The following is a description of a gene set: To better understand how innate immune responses to vaccination can lead to lasting protective immunity, we used a systems approach to define immune signatures in humans over 1 wk following MRKAd5/HIV vaccination that predicted subsequent HIV-specific T-cell responses. Within 24 h, striking increases in peripheral blood mononuclear cell gene expression associated with inflammation, IFN response, and myeloid cell trafficking occurred, and lymphocyte-specific transcripts decreased. These alterations were corroborated by marked serum inflammatory cytokine elevations and egress of circulating lymphocytes. Responses of vaccinees with preexisting adenovirus serotype 5 (Ad5) neutralizing antibodies were strongly attenuated, suggesting that enhanced HIV acquisition in Ad5-seropositive subgroups in the Step Study may relate to the lack of appropriate innate activation rather than to increased systemic immune activation. Importantly, patterns of chemoattractant cytokine responses at 24 h and alterations in 209 peripheral blood mononuclear cell transcripts at 72 h were predictive of subsequent induction and magnitude of HIV-specific CD8(+) T-cell responses. This systems approach provides a framework to compare innate responses induced by vectors, as shown here by contrasting the more rapid, robust response to MRKAd5/HIV with that to yellow fever vaccine. When applied iteratively, the findings may permit selection of HIV vaccine candidates eliciting innate immune response profiles more likely to drive HIV protective immunity. species: Homo sapiens Genes up-regulated in peripheral blood mononuclear cell Ad5 nAb titers >= 200Ad5 nAb titers <= 200 in adults (20-50) (Ad5 nAb titers > 200) after exposure to MRKAd5 HIV-1 gag/pol/nef, time point 1D. Comment: Impaired down-regulation. Genes with MRKAd5/HIV-induced expression responses significantly impacted by Ad5 nAbs (24hrs). Table includes specific cell types. Human Gene Set: ZAK_PBMC_MRKAD5_HIV_1_GAG_POL_NEF_AGE_20_50YO_AD5_NAB_TITERS_GTE_200_VS_LTE_200_1DY_UP from publication Zak DE, Andersen-Nissen E, Peterson ER, Sato A, Hamilton MK, Borgerding J, Krishnamurty AT, Chang JT, Adams DJ, Hensley TR, Salter AI, Morgan CA, Duerr AC, De Rosa SC, Aderem A, McElrath MJ (PMID 23151505), and this is the list of marker genes: MPRIP, NSA2 (NCBI Gene Id 10412), GPR174, TRGV3, C12orf57, PTGDR, TRAJ9, FCRL1, LDHB, TRAJ37, NT5E, SNORD4A, CSE1L, SESN3, TRBV19, PPIL3, PATJ, PRKACB, APBA2, DLEU1, SNORD8 (NCBI Gene Id 319103), TRAJ38, EIF3E, TRABD2A, NPAT, NAE1, THEMIS, RASGRP1, PSIP1, AK5, IP6K1, TRGJP1, STEAP4, SH2D1A, ZKSCAN8, KLRK1, G0S2, EIF3L, ITGB3BP, TRAV13-2, KLRD1, CD96, CAMK4, CD22, IPP, INPP4B, GTF2H3, CLEC2D, SCARNA5, TRAV20, RPL15, TRAV3, MGAT4A, ABCD2, GCC2, TRAV17, SESN1, ZNF506, FXR1, TRAJ41, TRAJ29, USP34, LRIF1, RORA, CYP27A1, TRAJ10 (NCBI Gene Id 28745), TRAJ48, CDCA7L, TRAJ5, TRAV8-2, ACADSB, HTATSF1, SKAP1, PAIP2B, RBL2, TRAJ40, NAP1L1, BMI1, ABLIM1, NAA16, SNORD5, TRAV41, SNORD4B, DENND4C, IGLV1-40, RPS13, TRAJ13, CRTAM, MAML2, TRAJ3, SLC4A7, KLRB1, KPNA4, KLRF1, NELL2 (neural EGFL like 2), DLGAP1-AS1 (DLGAP1 antisense RNA 1), LUC7L3, TRAV22, RCAN3, AHCTF1, BANK1, RNF125 (NCBI Gene Id 54941), H2AC8, ITGA6, DSC1, TTC3, MID2, ETS1, TLR10, PDE3B, TRAJ32 (NCBI Gene Id 28723), TRAJ36, TRAJ20, BCL2 (BCL2 apoptosis regulator), ZNF770, KLF12, N4BP2 (NEDD4 binding protein 2), NUCB2, TC2N, KLHDC2, TRAJ33, ERGIC2, SNORD116-14, TBC1D31, CRIPT, ARHGAP15, SLC38A1, SNORD6, IGF1R, ZNF84, CCR7, POLR1E, GZMK, USP53, RNF157 (ring finger protein 157), TRAV23DV6, NDUFS5, PLCB1, TRBV27, DPP4, AHNAK (AHNAK nucleoprotein), PWAR5, ITK, TRAJ45, TRBV4-2, ATPSCKMT, DOCK9, MS4A1, CD1C, PNN, FOXP1, SFPQ, CD3D, ZNF143, TRAV29DV5, AKR1C3, RPL17, SATB1, HLTF, TRAV19, TRAJ6, MPHOSPH9, TRAJ18, DPH5, AGL, TMEM204 (NCBI Gene Id 79652), BNIP3, IGHV3-21, TCL1A, CD27